Given this list of marker genes RIPK1, MIR92A1, TSPO, MIR107, CASP6, MIR103A1, PARP1, AIFM1, ZBP1, RIPK3, TP53, here is a description of the gene set: species: Homo sapiens Any process that increases the frequency, rate or extent of programmed necrotic cell death. Human Gene Set: GOBP_POSITIVE_REGULATION_OF_PROGRAMMED_NECROTIC_CELL_DEATH